Given this list of marker genes Bicd2, Agpat3, Tuba8, Tuba3b, Rab3gap2 (NCBI Gene Id 98732), Pla2g6, Tuba1c, Actr1a, Tubb6, Tubal3, Dctn1, Dctn6, Tubb4b, Actr10, Pafah1b3, Tubb2b, Rab18, Dync1li2, Tubb4a, Dynll1, Tuba1b, Tuba1a, Rab6a, Tuba4a, Galnt1, here is a description of the gene set: studied in species Mus musculus electronically inferred by orthology from the curated human pathway part of: Golgi-to-ER retrograde transport Reactome Pathway: COPI-independent Golgi-to-ER retrograde traffic This event has been computationally inferred from an event that has been demonstrated in another species.<p>The inference is based on the homology mapping from PANTHER. Briefly, reactions for which all involved PhysicalEntities (in input, output and catalyst) have a mapped orthologue/paralogue (for complexes at least 75% of components must have a mapping) are inferred to the other species.